The following is a description of a gene set: The series of molecular signals generated as a consequence of activation of the transmembrane protein Smoothened contributing to the dorsal/ventral pattern of the neural tube. Mouse Gene Set: GOBP_SMOOTHENED_SIGNALING_PATHWAY_INVOLVED_IN_DORSAL_VENTRAL_NEURAL_TUBE_PATTERNING species: Mus musculus, and this is the list of marker genes: Tbc1d32, Ift122, Gli3, Gli2, Wdr19, Tulp3, Gpr161